The following is a description of a gene set: Human Gene Set: HP_PERIPHERAL_OPACIFICATION_OF_THE_CORNEA Peripheral opacification of the cornea studied in species Homo sapiens Reduced transparency of the peripheral region of the cornea., and this is the list of marker genes: CHRDL1, APOB, MMP2, KERA, APOE, ALDH18A1, APOA1, GHR, SLC29A3 (NCBI Gene Id 8072), ABCG8, LCAT, APOA2, PPP1R17, EPHX2, LDLR, LIPC, PCSK9 (proprotein convertase subtilisin/kexin type 9)